Given this list of marker genes UBASH3B, CLIC5, PAM, MAPK4, HOXC13, GHDC, CDADC1, POLR2K, TENT5C, UBN2, SPEN, ARRDC3, MAPRE1, PINLYP, BTN2A1, CHIC1, FZD4, TOB1, C17orf75, PAX7, TBC1D16, CRKL, MON2, NUFIP2, RNF13, FGF18, STARD8, THRAP3, FPGT, BTK, MAGI3, HMGXB4, MNAT1, LY6K, GRIA3, RRN3, SAMD5, OTULIN, ITGB3, GOLGA4, CYRIA, TWIST1, THRB, PPP4R1, ADD2, EXOC5, EPHA3, ZNF589, TMEM169, ZNF770, MAB21L1, SMUG1, ATG7, C8orf44, MTMR4, SH3TC2, CACNA1E, MAPK10, C5orf63, SHISA7, MRE11, INA, CNOT6, BTN2A2, ZIC2, MAGEA9B, RIMS2, NEXN, SLCO4C1, RAP2C (NCBI Gene Id 57826), PRSS23, MCTP2, SENP2, TRPM4, ATL3, HEYL, CWC27, XPR1, CACHD1, PTGDR, PAPLN, FBXO28, GPR161, AIRIM, CLDN18, ZNF527, TNFRSF19, ADAM22, ELK4, MPPED2, FUT9, DPYS, CCDC158, BCL2L11, DCAF5, PTGFRN, CLGN, PIP4P2, BCLAF1, CCDC144NL, POLDIP3, ASPH, MFAP3, PKIA, MTCL3, KNSTRN, PADI3, ADGRL3, MADD, AXIN2, SVOP, FOXN1, PPP1R16B, NALF1, ZNF559, FAM210A, HAPSTR1, XPO7, GTDC1, HARS1, CSNK1G1, UGGT1, ANO6, R3HCC1L, RECK, ADM, EP300, RNPC3, ETS1 (NCBI Gene Id 2113), B3GLCT, GNAQ, UNC80 (NCBI Gene Id 84540), DSE, GRIP1, COMMD8, LHFPL1, KLHL18, ZNF704, ZNF384, ABCG4, AGO1, SEC14L4, PPFIA2, SRP19, RALY, ZBTB20, ZNF502, TMEM184B, ETAA1, TRAPPC11, PARPBP, RASSF3, ATE1, LRRTM2, PAX9, HMGN1, MAGEA9, here is a description of the gene set: Genes predicted to be targets of miRBase v22 microRNA hsa-miR-6780a-3p in miRDB v6.0 with MirTarget v4 prediction scores > 80 (high confidence targets). studied in species Homo sapiens from publication Chen Y, Wang X (PMID 31504780) Human Gene Set: MIR6780A_3P